Given this list of marker genes TNFRSF21, CBFA2T3, ASB7, LDLRAD3, FOXO1, ETF1, TUB, ATP1B4, MAT2A, DNAJB12, GOLPH3, GPC4, FBXO32, ITGB1BP1, IAH1, ZCCHC14, SMAD4, SPON1, PURA, SHISA7, TIMP2, KDM1B, SACM1L, TUSC1, ADGRG3, SMARCE1, PRKG1, PNRC2, CREBRF (CREB3 regulatory factor), here is a description of the gene set: studied in species Homo sapiens from publication Chen Y, Wang X (PMID 31504780) Genes predicted to be targets of miRBase v22 microRNA hsa-miR-4535 in miRDB v6.0 with MirTarget v4 prediction scores > 80 (high confidence targets). Human Gene Set: MIR4535